Given this list of marker genes Sfn, Rps27a, Dbf4, Mcm8, Cdc25c, H4c9, Pias4, Psma1, H4c2 (NCBI Gene Id 326620), Orc1 (NCBI Gene Id 18392), Orc4, H4c6, H2bc22, Mre11a, H2bc11, Top3a, Cdk1, Ywhah, H2bc1, H2bc15, Wrn, Orc3, Mcm7, Bard1, H2bc12, Ube2n, Psma4, Brca1, Mdc1, H2bc7, Psmc5, Ubb (NCBI Gene Id 22187), Psma6 (proteasome subunit alpha 6), H2ax, Psmb6, Psmd1, Orc5, Blm, H4c17, Babam1, Psmb7, H4c14, Psmd6, H4c4, Brcc3 (NCBI Gene Id 210766), Nbn, Psmc1, Mcm2, Psmd13, Psma2, Trp53 (transformation related protein 53), Dna2, Cdc7, Ccna1, H4c1, Gtse1, Rad9a, Psmb5, Hus1, Rpa1 (replication protein A1), Psmd12, Psmc6, H2bc3, Trp53bp1, Psmd7, Psmc2, H4c18, H4c11, Ywhae, H4c8 (H4 clustered histone 8), H2bc13, H4c3, Kat5, Cdc6 (cell division cycle 6), Psma3, Psmb4, Rad1, Psma7, Psma5, Rbbp8, Psmc3, Rnf168, Psmc4, H2bc8, H4c12, Wee1, H2bc9, Chek2, Mcm4, Ccnb1, Rfc3, H2bc27, Cdc45, here is a description of the gene set: Reactome Pathway: G2/M Checkpoints electronically inferred by orthology from the curated human pathway part of: Cell Cycle Checkpoints studied in species Mus musculus This event has been computationally inferred from an event that has been demonstrated in another species.<p>The inference is based on the homology mapping from PANTHER. Briefly, reactions for which all involved PhysicalEntities (in input, output and catalyst) have a mapped orthologue/paralogue (for complexes at least 75% of components must have a mapping) are inferred to the other species.